Given this list of marker genes SH3TC2, RAD21, COL9A2, GNPTAB, COL6A3, IPO8, ATP6V1E1, ACVR1, MYL2, YWHAE, EXTL3, COL10A1, HIVEP2, MYH7, ARSB, TAF1, MMP23B, SLC25A1, CHRM3, MAP3K20, COG6, RYR1, ECEL1, RAB11B, UBE4B, KANSL1, RERE, PORCN, SH3PXD2B, KAT6B, SIL1, KMT2D, SNRPB, HNRNPK, MYO9A, PIGW, MED12, COL5A2, NPAP1, NRCAM, OCA2, GABRD, HDAC4, ZBTB20, IARS2, CTCF, HDAC8, COL1A2, MMP13, OBSL1, PIGY, TRPS1, CLTCL1, FBLN1, ATP6V0A2, LETM1, SETBP1, PCNT, WDR19, LRP1, PPP2R1A, VAMP1, ATR, WNT7A, GLE1, CLCN3 (NCBI Gene Id 133073), CEP152, CHAT, TTN, UFSP2, ANKRD11, COMP, GLB1, EXT1, LONP1, DNAJC21, GMNN, ZFX, SMC3, FZD2, PPP2R3C, ADAMTSL2, VIPAS39, CNOT3, VPS33B, MATN3 (NCBI Gene Id 4148), SYT2 (synaptotagmin 2), BPNT2, TAF6, TPM2, MRPS25, UBA2, AGRN (NCBI Gene Id 389836), WNT5A, SNRPN, PDPN, ATP7A, GNPNAT1, POLR3A, PUF60, ZIC3, PIGV, TRPM3, KDM3B, NIN (NCBI Gene Id 57681, ninein), UMPS, NAA10, THRA, SHROOM4, GDF5, PGAP2, FHL1, PPP2R5D, CTBP1, BRD4, UNC45A, SIM1, ATP1A3, PIGO, TRAPPC11, SNAP25, PWAR1, ZNF469, TELO2, PGAP3, CCDC47, HOXA11, NFIX, SIX1, DHODH, ABCC9, NIPBL, PRDM16, USP7, SNORD116-1, ATAD3A, SLC5A7, MKKS, GEMIN4, CASZ1, SHPK, ATRIP, PWRN1, EP300, LUZP1, TPM3 (tropomyosin 3), SLC26A2 (solute carrier family 26 member 2), PAFAH1B1, COL1A1, BAP1, PIK3CA, DNA2, BICD2, SLC18A3, AHDC1, DPYSL5, RNF13, MAGEL2, EYA1, PHIP, CREBBP, RECQL4, GPC3, SLC35A3, MAP3K7, PLOD1, COL3A1, ATP6V1A, ATN1, B3GALT6, FLNA, COL6A1, ALDH18A1, RBBP8, KDM6A, PYCR1, CRELD1, SMARCA2, DDB1, COL13A1, DVL3, UBE3B, HERC2, THOC2, NSD2, TFE3, NSDHL (NCBI Gene Id 50814), CENPE, PRIM1, LGI3, IDS, KCNK4, PRKCZ, TBX4, ACTA1, NGLY1, MECOM (NCBI Gene Id 4197), CPLX1, USP9X, GLI3, FARS2, SLC2A10, SMC1A, PTRH2, ITGA7, TRAIP, NUP85, COL12A1, PRDM5, CUL7, KCNAB2, SRCAP, WDR26, NDN, PLK4, ADAMTS2, FIG4, MKRN3, KIF22, AXIN1, CCDC8, FGFRL1, HEATR3, TET3, MBD5, TBX15, HACD1, SNORD115-1, IRX5, COL2A1, LMNA, ARSK, SELENON, GNS, SPEN, HNRNPR, TRPV4, RAP1B, PIGL, TBCD, DVL1, GPC4, PIEZO2, EBF3, HSPG2, SKI, here is a description of the gene set: Human Gene Set: HP_HIP_DYSPLASIA The presence of developmental dysplasia of the hip. Hip dysplasia studied in species Homo sapiens